The following is a description of a gene set: The process in which a relatively unspecialized cell acquires the specialized features of a photoreceptor cell, as found in the eye, the primary visual organ of most organisms. species: Homo sapiens Human Gene Set: GOBP_EYE_PHOTORECEPTOR_CELL_DIFFERENTIATION, and this is the list of marker genes: PAX6, TULP1, MYO7A, GNAT2, PROM1, THY1, NTRK2, NAGLU, PDE6C (phosphodiesterase 6C), SOX8, CRB2, NRL, DIO3, THRB (thyroid hormone receptor beta), SDK2, NOTCH1, CEP290, RAB37, SAMD11, IHH, PPP2R3A, HCN1, BBS4, USH1C, VEGFA, TTC8, CNTF, SAMD7, AGTPBP1, RORB, GNAT1, RPGR, CRB1, PRDM1 (NCBI Gene Id 639), SOX9, NKD1, RDH13, RPGRIP1L, NDP, RP1, MFRP, TH, BBS10, ROM1, FSCN2, DZANK1, RPGRIP1, NR2E3, POC5, OLFM3, STAT3, CABP4, DSCAM, GNGT1, PRKCI